The following is a description of a gene set: studied in species Homo sapiens Genes down-regulated in CD8 T cells: naïve versus effectors. from publication Doering TA, Crawford A, Angelosanto JM, Paley MA, Ziegler CG, Wherry EJ (PMID 23159438) Human Gene Set: GSE41867_NAIVE_VS_EFFECTOR_CD8_TCELL_DN During acute viral infections, naïve CD8+ T cells differentiate into effector CD8+ T cells and, after viral control, into memory CD8+ T cells. Memory CD8+ T cells are highly functional, proliferate rapidly upon reinfection and persist long-term without antigen. In contrast, during chronic infections, CD8+ T cells become “exhausted” and have poor effector function, express multiple inhibitory receptors, possess low proliferative capacity, and cannot persist without antigen. To compare the development of functional memory T cells with poorly functional exhausted T cells, we generated longitudinal transcriptional profiles for each., and this is the list of marker genes: THUMPD2, SEPTIN2, HDAC3, COX18, SHMT1, RBMXL1, HAUS1, UQCC2, QNG1 (NCBI Gene Id 84267), INTS2, PUS1, DHRS4, EEFSEC, ARHGDIA, TRMT2A, GSDMD, STUB1, WDHD1, DYNLT2B (NCBI Gene Id 255758), NTPCR, HDGF, CYRIA, MRPS22, TEX10, TMEM209, RALGAPA2 (Ral GTPase activating protein catalytic subunit alpha 2), SHQ1, KPNA6, ABCD4, PSMB6, PPHLN1 (NCBI Gene Id 51535), CCT4 (chaperonin containing TCP1 subunit 4), DDX19A, HELLS, PREX1, SHH, TRMT10C, GEMIN2, PEBP1, NAA25, QTRT1, SLC25A39, NLE1, RANBP1, UROS, USP40, CCT3, EIF4E, SOD2, SMIM3 (small integral membrane protein 3), CAPRIN2, CYRIB, NT5DC1, SLC20A1, RCC1, RHBDF1, SNRPA, TRAPPC2, EIF2B1, SMPD4, BNIP1, ABCA5, NEPRO, CLUAP1, NOL11, PSMD10, DHX35, GATAD2A, ACP1, C1orf35, NOL8, ST3GAL4, LRPPRC, HUS1, PSMD6, IMMT, ELAC2, GRWD1, C1orf52, SOD1, TP53RK, SF3A2, GRPEL2, PPP1R14B, GK5, TSR1, NUP35 (NCBI Gene Id 129401), ELP4, COX10, POLRMT, ROMO1, RUVBL1, PA2G4, MRPS18B, DCAF13, LIPT2, NOP58, MED11, CCL17, SMN1, CORO1C, TTC27, COPS7B, ARV1, CSE1L, IPO11, IPO13, MRPL46, WDR3, ATP5F1D, E2F1, KPNA1, NEURL4, EXOC7, MTG1, AIMP2, TRAF1, SELENOH, MRPL36, NCOA5, AFG3L2, WDR83OS, NCF4, CHD1L, ZZZ3, FGF13 (NCBI Gene Id 730528), EXOSC8, LDLRAD3, MEMO1, SERPINB9, PLA2G4A, CCT2, GMNN, DBT, CLBA1, EIF2B3 (eukaryotic translation initiation factor 2B subunit gamma), CARNMT1, LSM7, FIG4, GABPB1, METTL22, RCC1L, OPA1, FKBP4, LRRC14, SMAD5, CYFIP1, TELO2, PRDX6, ZMIZ2, ANKRD26, PCTP, HDHD2, CHCHD6, DCPS (decapping enzyme, scavenger), POFUT1, WBP4, YWHAB, DNAAF5, NDUFAF5, POLDIP2, ADIPOQ, POLD2, LUC7L, C19orf48P, DNAJA1, KPNA4, LSM10, HNRNPAB, SDHAF1, RPP14, DTNBP1, ZSCAN22 (NCBI Gene Id 7601), SNAPC4, NEK4, SLIRP, TXNRD3, POLD1, PDCD11, ECD, PSMC2, DHPS, PCBD2, TRAF3, DUSP2, PTGES3 (NCBI Gene Id 10728), MTX3, MRPL55, URB2, MITD1, MRPS2, GCLM, RSL24D1, C1orf122, DTWD1, BCCIP, TMA16, CAMK2G, PFAS, BHLHE40